Given this list of marker genes ERF, VAC14, ARID1B (NCBI Gene Id 645070), IHH, NOG, SMARCA4, FIG4, WLS, here is a description of the gene set: species: Homo sapiens Hypoplasia of the phalanges of the toes Human Gene Set: HP_HYPOPLASIA_OF_THE_PHALANGES_OF_THE_TOES